The following is a description of a gene set: part of: Metabolism of water-soluble vitamins and cofactors species: Homo sapiens Folates are essential cofactors that provide one-carbon moieties in various states of reduction for biosynthetic reactions. Processes annotated here include transport reactions by which folates are taken up by cells and moved intracellularly, folate conjugation with glutamate (required for folate retention within a cell), and some of the key reactions in the generation of reduced folates and one-carbon derivatives of folate. Reactome Pathway: Metabolism of folate and pterines, and this is the list of marker genes: SLC19A1, MTHFR, FOLR2, MTHFD2, MTHFD1L, ALDH1L1, SHMT2, MTHFS, MTHFD2L, SHMT1, ALDH1L2, FPGS, DHFR, MTHFD1, DHFR2, SLC46A1, SLC25A32